Given this list of marker genes SLC18A3, ADORA2A, LAMA2, TACR2, TAC1, NALCN, TACR1, CHRNA3, ACHE, here is a description of the gene set: Any process that modulates the frequency, rate or extent of cholinergic synaptic transmission, the process of communication from a neuron to another neuron across a synapse using the neurotransmitter acetylcholine. studied in species Homo sapiens Human Gene Set: GOBP_REGULATION_OF_SYNAPTIC_TRANSMISSION_CHOLINERGIC